Given this list of marker genes KRTAP4-5, NCR3, BRSK1, METTL3, FIZ1, MAP1LC3B, CCDC167, RPAP3, KIAA1143 (KIAA1143), XPO6, CXXC1, TACO1, ZNF747, DAZAP1, GCC1, HSPBP1, RPL13A, NRSN2, PFKFB4, B9D2 (B9 domain containing 2), RAB7A, LRRC37B, ZNF614, LEMD2, SZRD1 (NCBI Gene Id 26099), DARS2 (NCBI Gene Id 55157), KCNIP2, NDRG3, KCNQ2, TMEM187, CCDC174, SLMAP, KCNH2, NR3C1, FARSA, OBSL1, RNU6-419P, SRFBP1, FAM117A, MIR4456, HNRNPUL1, SHLD1, ATP13A1 (NCBI Gene Id 57130), PCIF1, MYLK-AS1, HCFC1, ZMYM3, ATP8A2, TM9SF4, CENPL, FTSJ3, KLHDC9, PNPLA6, EXOSC2, SPACA3 (sperm acrosome associated 3), DYNC2I2, INHA, LRRC41 (leucine rich repeat containing 41), PRR14, ZNF785, DIO3OS, ATE1, TRMT12, MKKS, FUZ, SLC7A7, CHFR-DT, CIMIP5, ZFP37, USP31, RRM1 (ribonucleotide reductase catalytic subunit M1), ATG4B, DISP1, ZNF175, ARHGEF5, NOP53, GAP43, FBXO31, PRKCSH, BCL7A, IMP4, BCL9, NELFA, EIF4G2, RACK1 (NCBI Gene Id 90938), ATE1OSP, ZNF524, SH3BP5L, TMED10, KIRREL2, PSMB6 (NCBI Gene Id 95505), FBXO38, ZNF615, ZBED5-AS1, FOXA2, TUBA1A, RNF220, KAT7, CLK1, KNSTRN, YJU2, CCN1, UQCRH, ZNF585A, CAMKMT, HACD2, SLX4IP, ZNF649-AS1, GNAS, GHITM (NCBI Gene Id 27069), GFI1B, ODAD3, VPS35L, OXSR1, PRPSAP1, STAT6, PTP4A2, KNL1, EXOSC3, KIF15, C1orf174, NSD2, ZNF577, PTPA, MED25, TBC1D17, FEM1A, AKT1S1, PREPL, DPAGT1, MORF4L1, MIR3124, MIR4314, GCDH, CASC3, POGLUT1, ZNF300, CACNA1D, NKX6-3, ZNF747-DT, ACSM1, SCYL3, CDC45, EPIST, CARD10, CHFR, FCHSD2, ANAPC7, C2CD2L, COBL, MRPL52, NRSN2-AS1, CABIN1, UFD1, IPO8, DEDD, PLA2G6, CRADD, CPEB4, RIMBP3 (NCBI Gene Id 85376), SNX16, TUBA1C, TCP11L1, ZNF649, BSCL2, CRAT, CARD8, ZNF81 (NCBI Gene Id 7635), SPTBN4, MAP3K13, LCNL1, CAMLG, ZNF41, ZNF613, PSMB5, NAPEPLD, ZNF350, RPS19P1, BCAN-AS2, PTBP1, ZNF764, KLHL6, CDC42EP4, RICTOR, DAXX, LTF, SNORD95, STRIP1, TPGS1, SFSWAP, ZBED5, TBL3, CDK5RAP2, LINC01560, TSC22D4, CCDC115, ECH1, SPHK2, FGF10-AS1 (FGF10 antisense RNA 1), YWHAE, FGF10, TXNDC15, ARSA (NCBI Gene Id 410), FBXO38-DT, ZNF432, RIMBP3B, SLC16A5, TOMM40L, ZNF484, POLR1A, TMEM39A, HMOX1, RPS11, ARHGEF1, PSMC5, ENSG00000246308, TOR1A, TMCC2, FBXL19, TFAP4, PEX12P1 (NCBI Gene Id 647486), TGM2, ARAP3 (NCBI Gene Id 64411), THAP4, CCDC124, here is a description of the gene set: Human Gene Set: MCM3_TARGET_GENES Genes containing one or more binding sites for (MCM3) in their promoter regions (TSS -1000,+100 bp) as identified by GTRD version 20.06 ChIP-seq harmonization. species: Homo sapiens from publication Yevshin I, Sharipov R, Kolmykov S, Kondrakhin Y, Kolpakov F (PMID 30445619)